The following is a description of a gene set: Human Gene Set: REACTOME_SYNTHESIS_SECRETION_AND_INACTIVATION_OF_GLUCOSE_DEPENDENT_INSULINOTROPIC_POLYPEPTIDE_GIP species: Homo sapiens Synthesis, secretion, and inactivation of Glucose-dependent Insulinotropic Polypeptide (GIP), and this is the list of marker genes: SPCS2, ISL1, SPCS3, PAX6, SEC11A, DPP4, GATA4, PCSK1, GPR119, FFAR1 (free fatty acid receptor 1), GIP, SEC11C, SPCS1